Given this list of marker genes Ednrb, Syt4, Mdm2, Ptgds, Slc45a2, Aaas, Nnt, Sox10, Gpnmb, Cyp4f16, Ptp4a3, Mgmt, Zdhhc3, Ddit4l, Glrx3, Ephx1, Trpm1, Pmel, D630023F18Rik, Pcolce2, here is a description of the gene set: Mouse Gene Set: MCGOWAN_RSP6_TARGETS_UP Mutations in genes encoding ribosomal proteins cause the Minute phenotype in Drosophila and mice, and Diamond-Blackfan syndrome in humans. Here we report two mouse dark skin (Dsk) loci caused by mutations in Rps19 (ribosomal protein S19) and Rps20 (ribosomal protein S20). We identify a common pathophysiologic program in which p53 stabilization stimulates Kit ligand expression, and, consequently, epidermal melanocytosis via a paracrine mechanism. Accumulation of p53 also causes reduced body size and erythrocyte count. These results provide a mechanistic explanation for the diverse collection of phenotypes that accompany reduced dosage of genes encoding ribosomal proteins, and have implications for understanding normal human variation and human disease. Genes up-regulated by hemizygotic cre-lox knockout of RSP6 in keratinocytes. species: Mus musculus from publication McGowan KA, Li JZ, Park CY, Beaudry V, Tabor HK, Sabnis AJ, Zhang W, Fuchs H, de Angelis MH, Myers RM, Attardi LD, Barsh GS (PMID 18641651)